The following is a description of a gene set: Mouse Gene Set: GOCC_FEMALE_PRONUCLEUS The pronucleus originating from the ovum that is being fertilized. studied in species Mus musculus, and this is the list of marker genes: Stpg4, Mettl23 (NCBI Gene Id 76492), Tbp, Akap8, Cbx1, Slc2a1, Dppa3, Rif1, Tet3, Ccna2